The following is a description of a gene set: Bcl6 germline deletion causes a prominent inflammatory disease, owing to over-expression of Th2 cytokines, and affects the properties of B cells prior to immunization. Therefore we established the B cell-specific Bcl6 deletion mice and analyze the gene expression of naive B cells under physiological conditions. Genes up-regulated in follicular B lymphocytes: wildtype versus BCL6 knockout. species: Homo sapiens Human Gene Set: GSE28737_WT_VS_BCL6_KO_FOLLICULAR_BCELL_UP from publication Kaji T, Ishige A, Hikida M, Taka J, Hijikata A, Kubo M, Nagashima T, Takahashi Y, Kurosaki T, Okada M, Ohara O, Rajewsky K, Takemori T (PMID 23027924), and this is the list of marker genes: MARCHF9, CD22, MGAM, OGFRL1, DENND5B, ELANE, GRM3, LPCAT2, NETO2, FCHSD2, NSUN4, CYBB, CPNE4, SUSD5, CD74, PRX, SFT2D3, C5orf52, DUSP23, VASH1, FAM110A, CELF6, PHKA1, IGLL1, QSER1, UNC50, MUSTN1, KAZN, NXPH2, AGRN, COQ7, ANKRD26, CHI3L1, SLC6A19, NTS (NCBI Gene Id 96646), TMC2, PLEKHD1, PIM2, HTR2B, PER1 (period circadian regulator 1), CHAC1, NKPD1, FAM161A, WDR35, ZNF148, ACVRL1, FBXO24, HOXC13, MTCL1, NSL1, ZNF608, FFAR2, EYA1, NSUN5, P2RY1, NGF, RAD54L2, LAT2, SLC7A6, DLL1, S1PR3, CAD, TFRC, HLA-DQA1 (NCBI Gene Id 7946), TSPAN2, PLLP, STAT5A, TRIM46, SYCE2, CD79A, CLP1 (NCBI Gene Id 10978), CYTIP, PACSIN3, PPP1R12B, PLA2G1B, RPP40, SNX30, TEX13A, GPR143, ZNF451, EPS8, CYP3A7 (cytochrome P450 family 3 subfamily A member 7), MMP16, BFSP2, AGPAT4, FNTB, VWA3B, CD34, OPRL1, MEFV, CAPN11, ESAM, LIG3, SPC24, DFFA, YJEFN3, C3orf52, SECISBP2L, NPL, IRF4, TPX2, GNG11, PRKAG1, DBNDD1, HLA-DMB, MAP3K20, C19orf81, HYOU1, SNX9 (NCBI Gene Id 51429, sorting nexin 9), UAP1L1, RAB11FIP2, SYNPO2L, PILRB, SGPP2, ENPP1, ZNF106, CITED1, ZNF516, DLEU7, CTSH, TNFRSF13C, TNNI3, VAPB, BTK, CFAP91, MTFR2, PPM1K, KLHDC10, CCNO, BEX1, BDNF, HLA-DRB1, LYG2, PIAS2, GCNT1, MYH6, CLBA1, SKAP2, PLB1, IFNGR1, MCAT, SLC16A2 (NCBI Gene Id 6567), PPL, ST6GALNAC3, STAC, AK8, MAFF, TMEM67, TCEAL1, TAFA3, CCR6, CUL2, NCKAP5, FGF6, SBSPON, MFF, ZNF408, RASGRP3, EIF3B (NCBI Gene Id 8662), HSD17B1, CNTNAP1, KCTD14 (NCBI Gene Id 65987), PIK3R3, BSN, HOXA4, ITGB1BP2, SAPCD1, SELENOV, POM121, COQ5, EBF1, MC5R, NKAPD1, LY6D, HEY1, CCIN, THOP1 (NCBI Gene Id 92731), ENTPD8, CRB3, LRRC3, TBC1D9, ANGPT1, ARSJ (NCBI Gene Id 79642), IL31, DYDC1 (NCBI Gene Id 414183), HNRNPD (heterogeneous nuclear ribonucleoprotein D), GNAT2, SLC30A4, BLNK, HAVCR1, TNFRSF10A, CHRNB2, HHEX, SAC3D1, PRM2, EGR3, PTPN14, DKC1, ZMYM4, TDRD9